The following is a description of a gene set: The process that contributes to the act of creating the structural organization of the facial nerve. This process pertains to the physical shaping of a rudimentary structure. This sensory and motor nerve supplies the muscles of facial expression and the expression and taste at the anterior two-thirds of the tongue. The principal branches are the superficial ophthalmic, buccal, palatine and hyomandibular. The main trunk synapses within pterygopalatine ganglion in the parotid gland and this ganglion then gives of nerve branches which supply the lacrimal gland and the mucous secreting glands of the nasal and oral cavities. Human Gene Set: GOBP_FACIAL_NERVE_STRUCTURAL_ORGANIZATION species: Homo sapiens, and this is the list of marker genes: EGR2, NRP2, PLXNA3, HOXB2, SEMA3A (semaphorin 3A), HOXB1, NRP1, PLXNA4, SEMA3F